Given this list of marker genes Myb, Peli3, Kcnq5, E2f7, Zcchc3, Cdc25a, Tmcc1, Ddx3x, Onecut2, Ube2q1, Fgf7, Ccne1, Ywhah, Slc20a2, Slc25a22, Arih1, Slit2, Ccnt2 (NCBI Gene Id 97606), Arl2, 1700025G04Rik, Fam151b, Sptbn2, Pnpla6, Armcx6, Cdc37l1, Raf1, Sgk1, Gm12886, Zbtb34, Cldn12, Zfp809, Akap11, Atp2b2, Bmpr1a, Mob3b, Cntnap1, Spsb4, Tlk1, Ist1, Ccr2, Pla2g15, Fermt2, Suco, Ptpn4, Btrc, Zmym2, Atp7a, Rspo3, Znrf2, Pex13, Cfap45 (NCBI Gene Id 71870), Wfs1, Desi1, Sall1, Sall4 (NCBI Gene Id 99377), Axin2, Mybl1, Sik1, Dync1li2, Kcnk10, Rab11fip1, Acvr2b, Nectin1, Klhl2, Slc13a3, Pnp2, Akt3, Fbxo21, Rreb1, Atp1b4, Tuba4a, Hus1, Tmem87b, Nup210, Phactr2, Rnf10, Tacc1, Ccnd2, Kif5c, Arhgap12, Luzp1 (leucine zipper protein 1), Omg, Bicd1, Col12a1, Mob4, Ptprr, Mgat4a, Lurap1l, Sel1l3, Epha7, Jarid2, Ncapg2, Son, Wipi2, Eif3a, Higd1a, Chpt1, Klc4, Rad9a, Ppm1e, Reck, Tab3, Lats1, Klc1, Ttll6, Satb2, Prkar2a, Dll4, Klf14, Krtap26-1, Usp42, Ret, Rubcnl, Gpr63, Pik3r1 (phosphoinositide-3-kinase regulatory subunit 1), Gcc2, Arhgdia, Ccdc6, Kif23, Rfc1, Tgfbr3, Cyp26b1, Nos1, Capns1, Adgrl1, Rab9b, Capn6, Clspn, Smim13, Ints6l, Myt1l, Syde2, Bcl2, Ptpn3, Slc6a11, Usp12, Vtcn1, Zbtb39, Clock, Slc7a2, Hectd1, Tbl1xr1, Tmem135, Slitrk6, Dennd10, Phf20, Ccdc85b, Ski (ski sarcoma viral oncogene homolog (avian)), Adgrl2, Cmpk1, Map2k1, Pskh1, Nrn1 (NCBI Gene Id 68404), Lhx3, Kl, Ankrd13b, Itpr1, Pafah1b1, Slc4a7, Bcl2l2, Med1, Seh1l, Acox1, Dsel, Pam, Fasn, Cpeb3, Pnoc, Wbp11, Ubfd1, Tcaim, Btg2, Kif5b, Usp25, Ppp2r1b, Cert1, Nrbp1, Rasef, Kcnj2, Adissp, Wnt7a (wingless-type MMTV integration site family, member 7A), Nup50, Usp14, Prdm4, Esp36, Mmd, Sez6l, Grm7, Abtb2, Plxna4, Slc4a8, Pdxk, Akap7, Erc2, Tbpl1, Zbtb44, Penk, Zfp300, Cbfa2t3, Cdk5r1, Kif1b, Kctd8, Garem1, Tbp, Hoxa10, Pappa, Fmn2, Iars1, Srpra, Apln, Ippk, Qki, Atxn7l3, Cc2d1b, Mex3c, Cacul1, Zswim3, Adrb2, Dclk1 (doublecortin-like kinase 1), Unc80, Xpo7, Mapkap1, Nudt7, Il7r, Cpeb2, Ell, Lrrc32, Trank1, Rubcn, Pacsin2, Spred1, Cdca4, Usp31, Vegfa, Plxnc1, Nlrx1, Dll1, Ppp6c, Hectd4, Htr4, Spryd3, Ezh1, Helz, Nfatc3, Erlin2, Med26, Anks1, Nudt4, Tenm2, Kdsr, Rad23b, Nfe2l1, Fbln5, Rnf217, Smad7, Scoc, Ppp1r11, Plxna2, Gm5460, Zfp449, Rab10, Hapstr1, Cnot6l, Zyx, Acsl4, Phf19, Sec61a1, Slc25a37, Chac1, Plagl1, Tfap2a, Prrc2c, Cobll1, Kif21a, Kbtbd2, Septin2, Insyn2a, Avl9, Eda, Cdk12, B3gnt6, Kcnn4, Btbd8, Cd2ap, Pappa2, Drd1, Ago1, Shoc2, Zfhx4 (zinc finger homeodomain 4), Idh3a (NCBI Gene Id 76300), G0s2, Ash1l, Cbx4, Selenoi, Chek1, Angel1, Crebrf, Wee1, Sema3a, E2f3, Igf2r, Mfn2, Ube4b, Pwwp2b, Casr, Plekhh1 (NCBI Gene Id 97792), Armh4, Ubr3, Abhd13, Ncs1, Phip, Gpatch8, Polr3f, Rfx3, Wnt3a, Nav1, Crebl2, Sema6d, Dcp1a, Nol4l, Cbx6, Entpd7, Atxn1l, Nynrin, Wwp1, Bace1, Tmem178b, Traf3, Spag7, Pom121, Eya1, Stradb, Kmt2a, Cpd, Sec24a, Sox6, Tmem74b, Atxn2 (NCBI Gene Id 320857), B4galt1, Ythdc1, Socs6, Rere, Dnajc16, Usp15 (ubiquitin specific peptidase 15), Plpp1, Pth, Arfgap2, 2810459M11Rik, Cacna2d1, Slc4a4, Cdk17, Ago4, Wnk3, Rarb, Man2a2, Rasgef1b, Rnf144b, Zfp367, Lrig2, Setd3, Ankrd46, Plcxd2, Pou2f1, Dixdc1, Reln, Ahcyl2, 6430571L13Rik (NCBI Gene Id 235599), Plekhm3, Nuak2, Trp53inp2, Aff4, Csrnp1, Etnk1, Phc3, Trabd2b, Atg14, Rictor, Cpsf7, Ghr, Gbp2b, Abl2, Stxbp3, Krtap11-1 (keratin associated protein 11-1), Aar2, Chd2, N4bp1, Il10ra, Cops7b, Hmga1, Hephl1, Caprin1, Amotl1, Actr2, Pip4p2, Zfp622, Ppm1d, Adamts3, Atf6, Fgf9, Ano3, Tnrc6b (trinucleotide repeat containing 6b), Slc39a10, Acvr2a, Tll1, Colq, Lrig1, Smurf1, Dcaf7, Prmt6, Zfhx3 (NCBI Gene Id 68160), Sec14l1, Lrp6, Pip4p1, Ubn2, Rbm6, Nufip2, Ccnjl, Kpna1, Fbxw7, Fam135a, Islr, Sesn1, Kif1c, Zfp773, here is a description of the gene set: Mouse Gene Set: MIR_195B from publication Chen Y, Wang X (PMID 31504780) Genes predicted to be targets of miRBase v22 microRNA mmu_miR_195b in miRDB v6.0 with MirTarget v4 prediction scores > 80 (high confidence targets). species: Mus musculus